The following is a description of a gene set: The lipid bilayer surrounding a dense core granule. species: Homo sapiens Human Gene Set: GOCC_DENSE_CORE_GRANULE_MEMBRANE, and this is the list of marker genes: CADPS, SYT4, KIF1A (NCBI Gene Id 654843), SYT5, ADAM8, STXBP5, VPS13C